Given this list of marker genes Ptprb, Inip, Cyb5r3, Klf12, Arhgap6, Zfp462, Zfp654, Loxl2, Plxna4, Lrp4, Ogfrl1, Luc7l, Smim13, Arhgap15, Tnfaip8, Thbs1, Lrr1, Cipc, Prkce (NCBI Gene Id 98094), Nfix, Ica1l (islet cell autoantigen 1-like), Rlim, Krt26, Csrnp3, Lbr, Slc35f1, Ublcp1, Vcl, Cdh11, Cops3, Slc5a3, Nr2f2, Map7d2, Timm8a2, Sub1, Slc35b4, Vmn1r56, Pakap, Nucks1, Il12b, Eya4 (EYA transcriptional coactivator and phosphatase 4), Gins3, Zfp354b, Plpp6, Lbh, Plp1, Ncl, Pea15a, Col27a1, Gpd2, Syt12, Irx5, Pgm2l1, Lig4, Nhlh2, Cd164, Rgs4, Ccdc177, Slc24a2, Igf2bp2, Onecut2 (one cut domain, family member 2), Rab15, Fbxl5, Nkx2-3, Nudt12, Rad21, Pappa2, Bnc1, Hoxb4, Il12rb2, Tead2, Dcc, Cltb, Ark2c, Il1rl1, Sh3bp4, Tmem161b, Inpp5d, Rimklb, Rnf41, Ghsr, Gpr21, Tppp, Rab10, Zbtb41, Dstyk, Igsf9b, Nudcd2, Papola, Efr3b, Cd28, Herc1, Six6, Kif1b (NCBI Gene Id 16561), AW554918, Thsd7a, Siah1b, Cnih4, Mxd4, Lrp2, Tab3, Prss3b, Phactr1, Pcnx1, Prkci, Slc35e3, Ebna1bp2, Abl2, Lin7a, Gxylt1, Dcaf5, Casp3, Ablim1, Ralb, Dnajb5, Mgat2, Fbxo22, Avpr1b, Obox6, Tmem33 (transmembrane protein 33), Pten, Akr1c20, Nfib, Asxl2 (NCBI Gene Id 75302), Sgpp1 (sphingosine-1-phosphate phosphatase 1), Ssr3, Adgrf5, Egln3, Canx, Npr3, Arhgap32, Grm1 (glutamate receptor, metabotropic 1), Cemip2, Rasal2, Cybrd1, Cdk6, Atp1b4, Dyrk1a, Grxcr2, Atg2a, Pard3b, Neu3, Amotl1, Pnpla3, E130308A19Rik, Pou6f2, Robo1, Gpr174, Dnaaf6rt, Skint10, Stx16, Flrt2, Ugt2a3, Socs7, Cbx5, Rslcan18, Bcor, Slk, Lpp, Ywhah, Wee1, Spsb1, Kcnj2, Phex, Gria3, Rcbtb2, Fbxo33, Ceacam19, Kcnk10 (NCBI Gene Id 77454), Ct55, Mdga2, Prpf31 (pre-mRNA processing factor 31), Celf2, 1110059E24Rik, Siah1a, Igtp, Hspa2, Cygb, Dnaaf6, Tfap2b (NCBI Gene Id 98405), Kirrel2, Dlx5, Jun, Nr6a1, F13a1, Pdcl3, Camk2b, Prlr, Usp12, Apcdd1, Poglut3, Stard4, Isy1, Elmod2, Usp8 (ubiquitin specific peptidase 8), Nrbf2, here is a description of the gene set: from publication Chen Y, Wang X (PMID 31504780) Mouse Gene Set: MIR_12196_5P species: Mus musculus Genes predicted to be targets of miRBase v22 microRNA mmu_miR_12196_5p in miRDB v6.0 with MirTarget v4 prediction scores > 80 (high confidence targets).